Given this list of marker genes PRRT2, NPRL2, NUS1, SLC31A1, ATP1A3, GRIK2, PIGA, GRIN2B, SCN9A, DOCK7, COQ4, NHLRC1, CIC, CACNA1D, CNTN2, KCNH5, TGFB1, GABRA1, DEPDC5, GNAO1, LAMC3, FIG4, GABRD (NCBI Gene Id 2563), KCNB1, RERE, TBK1, SLC25A22, GJC2, CLN8, KCNT1, PDE2A, MTOR, CEP85L, LGI4, SPTAN1, KCNQ5, BRAT1, FRRS1L, SCN2A, GRIN2A, TBC1D24, GNB1, FGF13, GABBR2, CPA6, DNM1, CNTNAP2, SLC12A5, HTT, ADGRV1, AP2M1 (NCBI Gene Id 1173), CNOT1, ATXN10, OPHN1, KCNC2, VPS11, HID1, CDH2, CACNA2D1, TICAM1, PPFIBP1, OTUD7A, RELN (NCBI Gene Id 5649), LRP5, KMT2D, KCNQ2, PNPLA8, TRAF3, PLCB1, RNU12, TSC1, ITPR1, SCN3A, NSD1, ATP6V0C, GAL, NPRL3, STXBP1 (syntaxin binding protein 1), SUPT16H, PAFAH1B1, MACF1, ATP6V1B2 (NCBI Gene Id 526), KCNQ3, GAMT, FBXL4, MAST3, STRADA, FGFR3, AGO1, KDM6B, LGI1, EPM2A, MYT1L (myelin transcription factor 1 like), TRIM8, SCN8A, HCN1, GABRA3, PCDH19, CLCN4, PPOX, FMN2, ATP6V0A1, GABRG2, GNAI1, SLC32A1 (solute carrier family 32 member 1), ARHGEF9, CACNA1A, SCN1B, TSC2, VPS35L, TLR3, KDM6A, MICAL1, TANGO2 (transport and golgi organization 2 homolog), STX1B, CRIPT, CASR, CRELD1, APC2, ACSF3, SCN1A, UNC93B1, POGZ, CNPY3, ZNFX1, DNM1L, GNB2, GRIN1, CAMK2B, here is a description of the gene set: Focal impaired awareness seizure (or focal seizure with impaired or lost awareness) is a type of focal-onset seizure characterized by some degree (which may be partial) of impairment of the person's awareness of themselves or their surroundings at any point during the seizure. Focal impaired awareness seizure Human Gene Set: HP_FOCAL_IMPAIRED_AWARENESS_SEIZURE studied in species Homo sapiens